Given this list of marker genes Kcnk18, here is a description of the gene set: Reactome Pathway: TWIK-related spinal cord K+ channel (TRESK) This event has been computationally inferred from an event that has been demonstrated in another species.<p>The inference is based on the homology mapping from PANTHER. Briefly, reactions for which all involved PhysicalEntities (in input, output and catalyst) have a mapped orthologue/paralogue (for complexes at least 75% of components must have a mapping) are inferred to the other species. studied in species Mus musculus electronically inferred by orthology from the curated human pathway part of: Tandem pore domain potassium channels